Given this list of marker genes Traf3ip2, Vamp2, Ccl3, Ighe, F2rl1, Ccr2, Stx4a, Fcer1a, here is a description of the gene set: Any process involved in the carrying out of an immune response by an eosinophil. studied in species Mus musculus Mouse Gene Set: GOBP_EOSINOPHIL_MEDIATED_IMMUNITY